Given this list of marker genes CDK6, CDK4, CCND2, CCND3, CCND1 (cyclin D1), here is a description of the gene set: species: Homo sapiens Drug-mediated inhibition of CDK4/CDK6 activity Human Gene Set: REACTOME_DRUG_MEDIATED_INHIBITION_OF_CDK4_CDK6_ACTIVITY